The following is a description of a gene set: from publication Yevshin I, Sharipov R, Kolmykov S, Kondrakhin Y, Kolpakov F (PMID 30445619) studied in species Homo sapiens Human Gene Set: LMTK3_TARGET_GENES Genes containing one or more binding sites for (LMTK3) in their promoter regions (TSS -1000,+100 bp) as identified by GTRD version 20.06 ChIP-seq harmonization., and this is the list of marker genes: CYP26B1, SPESP1, IGLV3-6 (NCBI Gene Id 28806), MIR3677HG, GSTM5, SERPING1, FBF1, CINP, ZPR1, POP4, CWC25, GCNA, NUP155, RIN1, MAPK8IP2, LAMP1, FLNB, LARP1BP1, DNAJC30, SSNA1, SLC66A2, SOHLH2, PRSS12, KCNH2, ZNF785, MRPL4, DHDDS, MTHFSD, COL7A1, PINX1-DT, CEACAM8, MTFR2P2, IRGQ, MMP2, NHSL1, ELOC, MIR4453HG, POM121C, CDX1, DUS2, GPR78, CHRNA10, LTBP4, FAM86MP, ENSG00000231964, MIR4478, ABCC5, RNU6-638P, PGS1, AP1S3, MMP17, SLC25A34 (solute carrier family 25 member 34), SNORD83A, POLR3F, PLPP2, LYPD3 (NCBI Gene Id 94931), PELP1-DT, ITGBL1, TMEM132D-AS1 (NCBI Gene Id 283352), MIR4727, HAUS6P2, C11orf24, HGS, RPS6KB2, OFD1P17, RAD9A, SLC7A5P1, NAPA-AS1, HR, CLPTM1L, MRGPRF, RAPGEF3, RPL36AP39, TRUB1, IST1, WDCP, TMEM70, LRRC49, AARS1, ECD, EIF2B1, COMMD1, LMBR1, PRTN3, FLNB-AS1, EMC3-AS1, ZFAND2A-DT, PPIG, TMEM121, GAREM1, DPH3, ZNF710, GOLT1A, CACTIN, PHF19, NCBP2, PABPC1P4, FAM124B, ATG9B, COPS8, MAN1B1 (mannosidase alpha class 1B member 1), RPS6KL1, PTGES3P3, CCDC68, SRSF11, TRAF6P1, FRRS1L, COPS8-DT, KCNAB2, DGKD, GRM4, SEMA5B, GTF2H3, SPMIP1, CCT4, NOLC1, MAPKAPK5, TCF4-AS1, DHRS2, TWF1, UNC93B6, COX7A2L, C7orf50, PPP3R2, SLC35F5, RRM1, SEPTIN7P14, TENM2, TRIO, NDUFA10, YAP1P1, PARP4P3, CASKIN2, GLOD4, C19orf25, MED9, CASP4, LONP1, NEIL1, MRPL55, MTREX, BRSK2, API5P2, RPN1, PRRG3, IGHD2-21, MLLT6, CIDECP1, ITGAX, H1-8, CDK9, SEMA6A-AS1, LAMA5, GMIP, BCL9L, MAPK8IP3, NUP153, PELP1, SNORD55, CYP46A1, SPMIP5, CSNK1G2P1, CCDC86, SECISBP2, ADPGK, CTU2, ACAD9, BAP1, ITSN1, ENSG00000250075, ADAM32, LRRC40, TOX-DT, CSMD2, KCNQ2, TOMM6, RN7SL685P, DYNC1H1, ESPNL, FIRRE, VARS1, CMTR1, CYP2AB1P, FLII, LINC01947, PPFIA1, MMP16, LINC01347, SEPTIN7P2, PLXNA1, HSF2BP, BRD9, CYBA, PNLDC1, NDUFB6, NDC80, SRC, CNR1, RAPGEF5, STEEP1, TUBGCP6, DNAH17, USP51, PPP2R3B, ZC3H12D, MSX1, CRYBA2, NOX5, ZIC3, ANO5, ENSG00000259203 (novel transcript), CCDC59, IPO11, ZC4H2, SOBP, RPH3A, HAUS5-DT, AOPEP, MRPL57P3, SRRD, COLEC11, TOMM40P4, VGF, EMC3, ARMC9, LZTR1, EHMT1, RPL6, TMEM150C, PRSS16, CALN1, RMDN1, FAM187A, MED6, NPY5R, SLC38A3, RNU6-1232P, SNORA68B, REXO1, MED20, FBXW7, OR2W4P, SLC48A1, CCNA2, IGHMBP2, BAIAP2, PITRM1, RNY4P10, ELP5, KPTN (NCBI Gene Id 96493), CARD14, RLF, LINC02847, SPTLC1, NSG2, FTH1P5, STIMATE, CACNB2 (calcium voltage-gated channel auxiliary subunit beta 2), PLEKHG4B, COL23A1, RPAP1 (NCBI Gene Id 26015), RPS8, MN1, MFN2, CROCC2, RBM42, ARHGEF40, MTNR1B, SV2B, UNG, NOC4L, BDP1, NR0B1, TMEM94, ADSS1, RMDN3, MAS1LP1, EHMT2, GNAS, FAM149B1, ZFAND2A, AGRN, B3GNTL1, TATDN2P2, TOX, HDGFL3 (HDGF like 3), FBXL16, FAR2, ABCA3 (ATP binding cassette subfamily A member 3), PKMYT1, CYP2W1, ADAMTS18, PCDHA11, CNOT7, HSDL2-AS1, GPR148, WSCD1, ZNF576, PLEKHF2, EEF1B2P2 (eukaryotic translation elongation factor 1 beta 2 pseudogene 2), ANKRD20A19P, BCR, COPS7A, CADM1, ZNF721, RNU1-32P, VASH1, TRMT44, DPP6, DYNLT2, FGFR4, FLYWCH1, TMBIM6, CHMP1B (NCBI Gene Id 57132), TMEM132A, WDR75, TRMT61B, DZANK1, PCDH17, NIBAN3 (niban apoptosis regulator 3), CTNNBIP1, FOSL1P1, DHRS1, PCED1CP, LINC01414, NUBPL, ENSG00000232939, P2RX6, DGCR8, PCSK6, ACOT7, ECE2, COBL, WNT7B, LINC00606, CTDNEP1, PRKCD, KSR1, ANKRD13D, IFT52, C1D, TSC2, C6orf62, PHETA2, MAP2K3, B4GALT7, RNPS1, RANBP6, WDR13, CCDC191, TMEM208, QARS1, FAM99A, PIWIL1 (piwi like RNA-mediated gene silencing 1), UBN2, CIRBP, LINC01936, ZNF496, ENSG00000247416, DDX19A (DEAD-box helicase 19A), C16orf95, PRPF31, LINC02609, LINC01586, UBE2V2, GJC1, ARL5AP2, MRPL9, ADTRP, PPIL4, SPHK2, OXGR1, CTDP1 (CTD phosphatase subunit 1), VPS37A, AASDH, HMGB3P22, NUP214, PWP1, MIR6081, PTPN12, DHRS7B, RILPL1, ANAPC2, MAGOHB, PIGG, CNTN5, SLC30A8, C6orf136, HPYR1, SUN1, RNF150, FLJ30679, PTBP1, PKD1L1, ENSG00000228395, MIR34AHG, LINC02179, TUBA1C, TFPT, SSU72-AS1, TRIAP1, TESMIN, ARHGAP8, RAB6A, IGHD1-1 (NCBI Gene Id 28510), TMC6, CLN6, ZNF792, SAXO1, FAM237A, BUD23, TNFAIP8, SNED1, NCKAP5-AS2, TTC21A, GDF10, TSPAN18, SSU72, GARNL3, GTF2IP12, PKDCC, HSPA12A-AS1, MAMLD1, LRRC10B, LCN2, AKR1E2, POU5F2, ARX, GTF2IP13, TTYH1, METTL25, RUNX3, PELATON, MAF, SMAD6, SAG, LINC01264, UQCC4, RNF139, CRIM1, RASL12, FTH1P11, PTPN11, DDX51, DCLRE1C, RUNDC3B (RUN domain containing 3B), MED16, NPHP1, HOXD8, TRMT5, CWF19L1, SAXO5, FANCD2, ARHGAP27, MEG3, CCDC103, AJM1, RN7SL811P, SLC12A5, PRKRIP1, SENP5, ZBTB8B, PLAC9P1, KMT2B, RGMA, RPL3, SUPV3L1, NUBPL-DT, NCBP2AS2, RNU6-573P, FTCD, SPOUT1, DNAJB12, GATC, ENSG00000224865, OAZ3, KLC4, CDK18, FOXL2NB, TBL3 (transducin beta like 3), TSN, TBX18, ENSG00000283380, METTL4, SRRM5, PHF7, RBM20 (NCBI Gene Id 282996), SLC35E1, NOP9 (NCBI Gene Id 161424), ARHGAP6, MAP3K7, KLHL36, RXRB, IQSEC3-AS1, SLC38A6, NEURL1, BYSL, RMND5B, CCDC124, MRM3, ANKRD18B, RNF166, WDR59, MAPKAPK5-AS1, ADAR, ZNF614, ACTR10, SOD1, EIF2AK3-DT, ENSG00000260660, UGT1A4, EPHA10, BMERB1, HYOU1, KIAA1958, TCP10L2, RRP1B, PRICKLE2-DT, GPAM, RNF139-DT, RNVU1-1, LARP4B, WIZ, CGN, TRIM29, UPK3B, RCAN2, QTRT2, ANKRD26P1, PINX1, ERMARD, SNORD46, THAP4, INPP5K, TMEM39A, KCNIP1, AGTR1, GTF2IRD1P1, SF3B5, SMG1P7 (NCBI Gene Id 729513), WDR74, MAN2C1, AFAP1L2, EFTUD2, GTPBP10, ACOX3, HPS4, AKT1, SLC5A1, NOL4L, ZNF862, ZFR, RAI1, ANAPC4, NXF3, GNG4, HAUS5, CTDP1-DT, ISCA1P1, PFAS, C1orf127, TBCD, RNU6-1099P, ABR, OXNAD1, TMEM273, BLMH, GPAT3, FBLN1, SEPTIN5, LINC00174, UHRF2P1, ACSF3, CDK12, FBXL9P, RPL18, AMZ1, SGSM2 (NCBI Gene Id 9905), ARHGAP22, PABPC1L (NCBI Gene Id 80336), ABCB4, ATXN1L, MRPL2, SPACA9, SPTAN1, RHBDF1, HDGFL2, CENPW, ORMDL3, PSD2, RGL3, PLAGL1, INPP5D, ARHGAP45, AP2B1, TFAP4, PABIR1, PKP1